Given this list of marker genes Adnp, Nap1l5, Spock3, Pcdh8, Rragc, Trappc2, Ccnyl1, Krtap13-20, Ywhae, Ptgs1, Bcl11a, Sp3, Blzf1, Gnaq, Atp13a4, Usp9x, Cyp4a14, Cckar, Nr2e3, Usf3, Exo1, Polr2d, Ankrd12, Jmjd1c, Lmo4, Tcerg1, Dab2, Il2rb, Sub1, Abhd17c, Prrc2c, Ndst1, Traip (TRAF-interacting protein), Heatr5a, Tgfbr3, Tpx2, Slbp, Synpr, Il6st, Tfap4, Ces1d, Nfia, Phf20l1, Dnajc19, Ube2k, Usp1 (NCBI Gene Id 230484), Coil, Htr1f, Tex13c1, Ctnnd2, Cpeb3, Ift70a1, Rras2, Cstf3, Tspan2, Agpat5, Lpar4, Drd1, Cdh2, Adam22, Wapl, Rptor, Acvr2a, Mgat4a, Mrs2, Wee1, Rubcnl, here is a description of the gene set: Genes predicted to be targets of miRBase v22 microRNA mmu_miR_7072_3p in miRDB v6.0 with MirTarget v4 prediction scores > 80 (high confidence targets). Mouse Gene Set: MIR_7072_3P species: Mus musculus from publication Chen Y, Wang X (PMID 31504780)